The following is a description of a gene set: species: Homo sapiens Broad eyebrow Human Gene Set: HP_BROAD_EYEBROW Regional increase in the width (height) of the eyebrow., and this is the list of marker genes: ACTB, FRA10AC1, CASP2 (NCBI Gene Id 835), ZFX, BPTF, ZEB2, HERC1, CHD1 (NCBI Gene Id 1105), MAPK1, MAN1B1, TRMT1, SPTBN1, FBXO11, SON, CREBBP, AFG2A, SIN3A, POLR3A, DDB1, EP300, KMT2A, NEPRO, PYCR2, EIF5A, TTC5, SLC35C1 (solute carrier family 35 member C1), MAB21L1, POLA1, RERE, MAF